Given this list of marker genes Ptgs2, Naglu, Abcc8, Ptgs1, Zeb2 (zinc finger E-box binding homeobox 2), Slc1a1, Ifnb1, Tspan12, Vegfa, Mfsd2a, Tjp3, Sh3gl2, Tjp2, Angpt1, Ocln, Cldn5, Cd2ap, Abcb1a, Tjp1, Wnk3, Mbp, Slc12a2, Bdkrb2, here is a description of the gene set: species: Mus musculus Mouse Gene Set: GOBP_MAINTENANCE_OF_BLOOD_BRAIN_BARRIER Maintaining the structure and function of the blood-brain barrier, thus ensuring specific regulated transport of substances (e.g. macromolecules, small molecules, ions) into the brain, and out of the brain into the blood circulation.